The following is a description of a gene set: species: Homo sapiens Human Gene Set: GATA6_01 Genes having at least one occurrence of the motif NNNGATWANN in the regions spanning 4 kb centered on their transcription starting sites. This matches the GATA6 transcription factor binding site V$GATA6_01 (v7.4 TRANSFAC)., and this is the list of marker genes: ITGB3BP, TFR2 (NCBI Gene Id 7036), MYO1C, PDZD2, COL4A4, AQP3, TYRO3, SFRP5, PCDH9, BRWD3, FOXH1, SSTR3, KCNH5, KLB (NCBI Gene Id 152831), MMP23B, ABCB5, ISL1, RBFOX1, FMO1, RFESD, TNK2, FOXA1, APMAP, SPOP, CLEC18C, PDGFRA, ENO2, MATN1, TLE4 (NCBI Gene Id 7091), LMO3, STC1, SAXO4, RUNX1T1, PFKFB1, WWP2, ESRRB, NECTIN2, DIAPH3, ZFPM2, SNTG1, PYY, MYBPC3, ERRFI1, LECT2, CREB5, PLAGL2, TBX4, TSPAN32 (NCBI Gene Id 10077), TMEM71, ESRRG, SKIL, ADCY6, SOBP, TACC1, PHC2, RNF186, TAB3, TGIF2, MMP23A, NOG, BMP6, CIAO2A, LGSN, ADCYAP1, VIT, IRAG2, RGS3, IL7, LEPROT, PITX2, CTSE, SERPINB4, CDON, ST13P4, HOXB6, GABRA2, PSMA1, KIZ, MID1, CS, POU2AF1, MYRF, MASP1, GFRA3, ASPHD1, KRT77, ZNF781 (zinc finger protein 781), NR2F2, GATM, GBX2, STON2 (NCBI Gene Id 85439), TSC22D1, REG4, ZBTB7A, LEPR, URM1, HOXB3, BIN1, OTX2, BCL6, OLFML3, RBPMS, PTGDR2, SYVN1, TFAP2D, SLITRK2, SIX1, BPGM, TBX5, SALL2, PIP5K1B, LYL1, TIAL1 (NCBI Gene Id 8430), KRT15, MTTP, TRPS1, ANKS1B, DOCK8-AS1, PSD4, FAM91A1, NRAS, ACKR1, BTG2, CDIN1, CMTM6, XPO6, MOS, WAPL, CDH2 (cadherin 2), NR5A2, FOXP1, USP26, DDR2, NCKAP5, ATP6V0A4, LIMS1, ARAP2, SYNDIG1, CFAP161, ECT2, HS3ST5, ECHDC2, ZBTB7B, POFUT1, FBRS (fibrosin), DENND1B, LRGUK, CELF4, CACNB2, HOXA1, ATP2A3, PNLIP, HPSE2, EYA1, FAM107B, TNFSF10, SLC39A14, LIX1, PNLIPRP1, SGIP1, RUNX2, POU4F2, KRT23, LUC7L3, TCP11L2, KCNK5, PPM1E, ERG, UBE2H, CASZ1, SORBS1, SLC18A1, SETD2, CPA1, ZNF219, FABP2, HOXA4, ANGPT2, CDC42EP3, CARD6, TAFA1, LHX6, JARID2, TAOK2, MYCT1, ETV6, ARHGEF10L, LRCH2, FST (NCBI Gene Id 10468, follistatin), PUM2, COX8C, FOSL2, PKIA, VSNL1, AQP1, RNF112, EEF2KMT, SFRP1, PWWP2B, SOX5, LSAMP, PDE3B, MND1, CLRN3 (clarin 3), SRGAP1, NOCT, PRRX1, ITPR1, GSC, MOGAT2, FAM72A, GATA6, DCX, FSIP2, SPINK4, LINC00656, CTCF, DSPP, GPBP1, SLC10A2, CACNA2D3, IQGAP1, RAI1, NR2F1, SMAD5, DOCK8, BCO1, MEF2C, UPP1, SKIDA1, PLXNA2, GREB1 (NCBI Gene Id 9687), CXCL13, EDA (ectodysplasin A), WNT11, RORB, PTPRG, VAX1, EPB41L3, KDM6A, KLF12, TSPAN12, AHCTF1, COL4A3, SCUBE3, IGFBP5, KCNJ15, GATA1, RHAG, ASCL2, TGIF1, HOXC4, RSBN1L, GPR155, SYT7, TPH2, KDM3A, CTNNA3, SNX1, ST13P5, HNRNPA2B1, ELAVL4, ETV5, BSN, ZMYND8, PLAC1, PPARGC1A, SPRY4, CNTLN